Given this list of marker genes Fosb, Ifngr1, Bin1, Jun, Clec12a, Gdi2, Cd44, Dusp1, Ramp1, Atp5mc2, Hepacam2, Arhgap31, Pdcd4, Klf2, Lyz2, Eif3k, Niban1, Uba52 (ubiquitin A-52 residue ribosomal protein fusion product 1), Tsc22d3, Rgs1, Kctd12 (NCBI Gene Id 239217), Klf6, Eef2, Syne1, Fos, Cldn1, Cd81, Pold4, Klf4, Npm1, Adrb2, Pid1, here is a description of the gene set: studied in species Mus musculus Mouse Gene Set: CUI_CDC1_IFNK_RESPONSE_DN from publication Cui A, Huang T, Li S, Ma A, Pérez JL, Sander C, Keskin DB, Wu CJ, Fraenkel E, Hacohen N (PMID 38057668) Cytokines mediate cell-cell communication in the immune system and represent important therapeutic targets. A myriad of studies have highlighted their central role in immune function, yet we lack a global view of the cellular responses of each immune cell type to each cytokine. To address this gap, the authors created the Immune Dictionary, a compendium of single-cell transcriptomic profiles of more than 17 immune cell types in response to each of 86 cytokines (>1,400 cytokine-cell type combinations) in mouse lymph nodes in vivo. A cytokine-centric view of the dictionary revealed that most cytokines induce highly cell-type-specific responses. For example, the inflammatory cytokine interleukin-1β induces distinct gene programmes in almost every cell type. A cell-type-centric view of the dictionary identified more than 66 cytokine-driven cellular polarization states across immune cell types, including previously uncharacterized states such as an interleukin-18-induced polyfunctional natural killer cell state. Genes negatively differentially expressed in cell type: cDC1 (conventional dendritic cell type 1) upon treatment with cytokine: IFN-κ in mouse lymph nodes in vivo.